Given this list of marker genes SIRT6, SIRT1, PARP4, TNKS2, TNKS, QPRT, SIRT2, SIRT5, ACMSD, CD38, NAMPT, SIRT4, BST1, PARP2, NADSYN1, SIRT7, TDO2, NMNAT1, IDO1, SIRT3, PARP1, NAPRT, here is a description of the gene set: species: Homo sapiens Human Gene Set: WP_NAD_BIOSYNTHETIC_PATHWAYS NAD+ biosynthetic pathways